The following is a description of a gene set: Genes in the cancer module 495. species: Homo sapiens Human Gene Set: MODULE_495, and this is the list of marker genes: LEAP2, NECTIN2, C2CD4C, ICAM4, IL1RAP, RCBTB2, VRTN, CDADC1, RGS1, HGD, PPP4R4, XPNPEP2, CKAP2, CCDC68, LRRN3, SULT1E1 (sulfotransferase family 1E member 1)